The following is a description of a gene set: Human Gene Set: HUMMERICH_MALIGNANT_SKIN_TUMOR_DN Genes down-regulated in malignant skin tumors (squamous cell carcinoma, SCC) formed by treatment with DMBA and TPA in the two stage skin carcinogenesis model. Chemically induced mouse skin carcinogenesis represents the most extensively utilized animal model to unravel the multistage nature of tumour development and to design novel therapeutic concepts of human epithelial neoplasia. We combined this tumour model with comprehensive gene expression analysis and could identify a large set of novel tumour-associated genes that have not been associated with epithelial skin cancer development yet. Expression data of selected genes were confirmed by semiquantitative and quantitative RT-PCR as well as in situ hybridization and immunofluorescence analysis on mouse tumour sections. Enhanced expression of genes identified in our screen was also demonstrated in mouse keratinocyte cell lines that form tumours in vivo. Self-organizing map clustering was performed to identify different kinetics of gene expression and coregulation during skin cancer progression. Detailed analysis of differential expressed genes according to their functional annotation confirmed the involvement of several biological processes, such as regulation of cell cycle, apoptosis, extracellular proteolysis and cell adhesion, during skin malignancy. Finally, we detected high transcript levels of ANXA1, LCN2 and S100A8 as well as reduced levels for NDR2 protein in human skin tumour specimens demonstrating that tumour-associated genes identified in the chemically induced tumour model might be of great relevance for the understanding of human epithelial malignancies as well. from publication Hummerich L, Müller R, Hess J, Kokocinski F, Hahn M, Fürstenberger G, Mauch C, Lichter P, Angel P (PMID 16247483) studied in species Mus musculus, and this is the list of marker genes: MYH8, SCAND1, MYL11, MYH2, RETNLB, AFF1, TNNT3, PCDH12, IFI27L2, CA3, SNX7, TNNC2 (troponin C2, fast skeletal type), TNNI2, COX6A2, ATP2A1, PLXNB2, CFD, CKM, CCL27, ALB